The following is a description of a gene set: Human Gene Set: GOBP_TISSUE_REGENERATION The regrowth of lost or destroyed tissues. species: Homo sapiens, and this is the list of marker genes: GNAT1, FZD9, APOD, AKIRIN1, CD81, MIR590, MCUB, CDKN1B, GAP43, XIRP1, TMEM182, IGFBP1, NOTCH1, ERBB4, BIN3, CPQ, DAG1 (dystroglycan 1), B4GALNT2, MIR199A1, WNT7A, WNT10B, PLG, VPS54, LARGE1, MIR29B1, NINJ1, MYMX, POSTN, SELENON, PAX7, CD9, RUNX1, HDGFL2, ASCL3, MYOZ1, P2RX5, TARBP2, SOX15, CCNB1, PTN (NCBI Gene Id 5764), EPPK1, FZD7, IGF1, GPX1, ANXA1, PTPN12, GATA4, APOA5, MYOD1, MUSTN1 (musculoskeletal, embryonic nuclear protein 1), FGF10 (fibroblast growth factor 10), MDK, NACA, YAP1, CDKN1A, IFRD1, PPP3CA, MSTN, TEC, CFLAR, KPNA1, GNAT2, EZH2 (NCBI Gene Id 392834), SPAAR, GJD4, MYMK, TM4SF4, EYS, KLF5, LGR6, HOPX, CCN3 (cellular communication network factor 3), PTGFRN, NINJ2, ADAM15 (NCBI Gene Id 8751), PPARD, FKRP, MYF6, CAPN3, COL6A1, SOX2, KLK6, BCL9, DUSP10